Given this list of marker genes Pak1, Nptn, Cnrip1, Cnr2 (NCBI Gene Id 12802), Bdnf, Plg, Grm5, Syt4, Nrxn3, Igsf21, Slitrk5, Cbln2, Plat, F2r, Gucy1a1, Efnb3, Ntrk2, Cbln4, Cbln1, Neo1, Nrxn1, Faah (NCBI Gene Id 14073), here is a description of the gene set: Cell-cell signaling between presynapse and postsynapse, across the synaptic cleft, that modulates the synaptic transmission properties of the synapse. Mouse Gene Set: GOBP_TRANS_SYNAPTIC_SIGNALING_MODULATING_SYNAPTIC_TRANSMISSION studied in species Mus musculus